The following is a description of a gene set: species: Mus musculus from publication Yao MW, Lim H, Schust DJ, Choe SE, Farago A, Ding Y, Michaud S, Church GM, Maas RL (PMID 12554760) Human Gene Set: YAO_TEMPORAL_RESPONSE_TO_PROGESTERONE_CLUSTER_0 Genes co-regulated in uterus during a time course response to progesterone: SOM cluster 0. Human infertility and recurrent pregnancy loss caused by implantation defects are poorly understood. Hoxa-10-deficient female mice have severe infertility and recurrent pregnancy loss due to defective uterine implantation. Gene expression profiling experiments reveal that Hoxa-10 is an important regulator of two critical events in implantation: stromal cell proliferation and local immunosuppression. At the time of implantation, Hoxa-10 mediates the progesterone-stimulated proliferation of uterine stromal cells. Hoxa-10 mutants express a stromal cell proliferation defect that is accompanied by quantitative or spatial alterations in the expression of two cyclin-dependent kinase inhibitor genes, p57 and p15. Hoxa-10 deficiency also leads to a severe local immunological disturbance, characterized by a polyclonal proliferation of T cells, that occurs in place of the normal progesterone-mediated immunosuppression in the periimplantation uterus., and this is the list of marker genes: DBP, CTSF, NGEF, LIFR, GABARAPL1, ABCA4, CCNG2, LAMB3, HSD17B11, CEBPD, CFH (NCBI Gene Id 3076), NR1D1, GEM, PNPLA2, AOX1 (NCBI Gene Id 316), NR1D2, GLRB, ENPP2, SASH1, FOXP1, RIN2, MET, RECK, NREP, CASP4, LDAF1, ATP1A2, NCAM1, DDX6, BACH1, TXNDC16, PROM1, C5orf34, ADRB2, LAMA3, RAD51B (RAD51 paralog B), RORA, RHOQ, ABCA1, ST6GAL1, MAP1LC3B, CREBRF, ANGPTL2, CPD, ALDOC, BBS9, BNIP3, IGFBP3, PROS1, SMPDL3A, EPS8, WDR45, ALAS1, PLA2G7, ABLIM1, MYCL, MXI1, YPEL3, NT5E, SESN1, ITIH5, HLA-B, RTN2, EPHX1, GSTT2, LOX, KLHL24, CYP4V2, DKK3, TEF, HAUS4, VAMP4